The following is a description of a gene set: The chemical reactions and pathways involving any of the forms of vitamin K, quinone-derived vitamins which are involved in the synthesis of blood-clotting factors in mammals. Vitamin K substances share a methylated naphthoquinone ring structure and vary in the aliphatic side chains attached to the molecule. Human Gene Set: GOBP_VITAMIN_K_METABOLIC_PROCESS species: Homo sapiens, and this is the list of marker genes: NQO1, CYP4F12, UBIAD1, VKORC1, CYP4F11, CBR1, CYP4F3, CYP4F2, AIFM2, CYP4F8, VKORC1L1, GGCX, CBR3